Given this list of marker genes SHISA3, ZFP2, DEGS1, SLC25A37, REG3A, UNC119B, CREB3L2, PRKACA, QTRT1, EBP, TACC1, PRKCI, CCAR2, ANKRD52, LAMTOR1, HELB, CNPY4, RABEP1, ENTPD5, RHBDD2, SLC15A4, PPA2, INSR, MRPL23, MICU3, DHX16, TMEM14C, TXNL4B, P4HTM, HEBP1, ARF3, RER1, MAP2K6, MN1, ZDHHC9, TTC38, NEXMIF, SPIRE1, SEPTIN8, TXNDC11, EZH1 (enhancer of zeste 1 polycomb repressive complex 2 subunit), XPR1, ISCA2, COA4, FBF1, MBTPS1, CKAP2, RPS16, BORCS8 (BLOC-1 related complex subunit 8), METTL6, COL17A1, SREK1IP1 (NCBI Gene Id 285672), JAGN1, PSAT1, INIP, ATG16L2, LSS, TARS2, PDPR, PTRH2, ZDHHC16, XRCC6, PRAM1, MTAP, YDJC, MGME1, MTRFR, TNNT3, MARVELD1, MAK16, MEGF9, TNRC6A, MIB2, SGSH, TXNDC5, OPA3, BLOC1S5, DENND2C (DENN domain containing 2C), VPS16, GDPD3, PREB, SH2B2, FRRS1, TBC1D14, PRMT3, PPP2R3A, FAM8A1, TEN1, MXD4, RAD51D, HDHD2, ELP1, ZNF667, PPP1R18, MECR, FBRSL1, APOBR, PCNX3, SCAP, TMC6, BRWD1, PIGV, CCNDBP1, B3GALNT1, TTC13, TPRA1, KCNJ16, CLEC11A, FPGS, TSC22D4 (TSC22 domain family member 4), PLXDC1, SPECC1L, PHB2, HDAC10, PDSS2, METTL1, KLHDC10, LMNB2, PON3, TMEM198, TCP11L2, DTD1, AGPS, SGIP1, NPEPL1, SNRNP48, TMEM223, SMPD2, ALG9, CLEC4G (NCBI Gene Id 339390), PPP2R1A, LRP1, ECI1, LYL1, BRMS1L (NCBI Gene Id 84312), HNRNPR, CENPO, CLPTM1L, TYW1, CTCF, DNASE1L2, MGST3, YPEL2, SLC6A13, SLC30A9, TMEM203, RPL18, TRAF3IP1, LMF1, PIP5KL1 (phosphatidylinositol-4-phosphate 5-kinase like 1), KATNB1, EMC10, POLH, DALRD3, STIMATE, PYGB, SUMF2, MCTP1, RAB11FIP5, TMEM106C, PPRC1, MPC2, DUSP12, ERCC5, LCLAT1, NADSYN1 (NAD synthetase 1), IMP3, C5orf24, FAM98C (family with sequence similarity 98 member C), ARHGAP39, PLEKHG3, MRPL33, MLH3 (mutL homolog 3), SLC25A35, MAPK7, ZNF496, RNF187, ATIC, KLHDC2, SLC1A5, POLR1A, ZNF692, DTWD2, WDR55, ACAT2, LZTR1, DHX34, F8A1, GORASP2, TNNI3, DHDDS, JOSD2, MEN1, ANXA6, TEF, STAG3, EIF2B4, METTL26, ASNSD1 (NCBI Gene Id 54529), here is a description of the gene set: from publication Kaji T, Ishige A, Hikida M, Taka J, Hijikata A, Kubo M, Nagashima T, Takahashi Y, Kurosaki T, Okada M, Ohara O, Rajewsky K, Takemori T (PMID 23027924) Bcl6 germline deletion causes a prominent inflammatory disease, owing to over-expression of Th2 cytokines, and affects the properties of B cells prior to immunization. Therefore we established the B cell-specific Bcl6 deletion mice and analyze the gene expression of naive B cells under physiological conditions. studied in species Homo sapiens Human Gene Set: GSE28737_FOLLICULAR_VS_MARGINAL_ZONE_BCELL_UP Genes up-regulated in follicular B lymphocytes versus marginal zone B cells.